The following is a description of a gene set: The process in which the structure of the aortic valve is generated and organized. studied in species Homo sapiens Human Gene Set: GOBP_AORTIC_VALVE_MORPHOGENESIS, and this is the list of marker genes: BMP4, GATA5, HEYL, SNAI1, RHOA, SLIT2, TWIST1, SOX9, GATA3, TIE1, TBX20 (NCBI Gene Id 57057), TGFBR2, SNAI2, ROBO2, JAG1, EFNA1, GATA4, NOS3 (nitric oxide synthase 3), ROCK2, ADAMTS19, RB1, TGFB1, HEY2 (hes related family bHLH transcription factor with YRPW motif 2), DLL4, NOTCH1, ADAMTS5, SMAD6, NKX2-5, ELN, EMILIN1, NPPA, AXIN2, SMAD2, ROCK1, ROBO1, HEY1, CDH11, SLIT3, NFATC1